Given this list of marker genes CST4, ACOT7, RAP2A, MDH1, HMOX2, NCAPH, CHD1L, EPAS1, VASH1, MRPL4, UQCRB, SREBF1, ATP1B1, GPR146, PCBP2, MAP2K6, GSE1, CBX6, ANKMY2, PRDX2, CNDP2, RAB33A, TMEM273, CBR3, PIAS2, HAVCR2, CBS, CD200R1, C1orf54, EPB41L2, NAGPA, SLC49A4, SAMD13, SLAMF9, CLASP2, RRP1B, ISOC2, CCDC6, ALDH1A2, HSD11B1, EEF1AKMT3, DIPK1A, RAD18, CD276, CD1B, AKAP5, TMC6, DHCR24, SCD (NCBI Gene Id 6319), CALCRL, AP3M2, HMG20B, B3GNT2, MYC, RAMP1, SLC16A1, TMCO4, SUCNR1, ITGAM, HSP90AB1, CTNNAL1, CCL22, SEPTIN11, ARL2, KLHDC9, SPP1, SGPP1, NIBAN1, CCDC92 (coiled-coil domain containing 92), EXTL2, CCL17 (NCBI Gene Id 6361), A2M, LINC02431, CD226, IL21R, CCND2, ADORA3, HIVEP3, CCDC85B, CFL2, SPN, TTL, CHCHD10 (NCBI Gene Id 400916), DHRS11, MLLT11, ERI1, ITPRIPL1, DNPH1, FOXQ1, MREG, HS2ST1, VAT1, KLF4, TPI1, BCO2, ZNF846, PPARGC1B, MIR503HG, DCSTAMP, C11orf21, MTHFD1L, HYCC1, PXYLP1, SYT17, TMEM266, SLC5A3, GALNT18, HEMK1, GDPD1, TBX19, PVT1, DNPEP, ILVBL, MAP3K21, GANC, C3orf18, HK3, CH25H, UQCRC1 (NCBI Gene Id 7384), SLC16A2, GARS1-DT, CLCN5, SENCR, PER2, NFIL3, PKD2, EFCAB11, C17orf58, ZNF571, MCUR1, LIMA1, CCL13, KHSRP, CSNK2B, UBE2F, ZNF93, SLC27A3, LNPK, CD81, PDCD1LG2, CD1A, SNHG33 (small nucleolar RNA host gene 33), FAM86B1, ATL1, WDR41, STUB1, NIPA1, RAP1GAP, MFHAS1, PCBD1, ZXDB, ZCCHC2, AUH, HOMER2, DEFB114, RHBDF1, CCL26, CD200, PRKD3, ADCK2, GOLGA8A, LDLRAD4, ROGDI, PER3, ZNF589, BCAR3, HSPB1, STARD4, JAG1, CLEC1A, RASAL2, ALOX15, CD209, ARAP2, STRADB, SNAI3 (snail family transcriptional repressor 3), NHLRC3, WFS1, NIFK-AS1, CRIP1, PFKP, TREM2, GTF2IRD1 (NCBI Gene Id 9569), GPI, CD1C, GSPT2, IFT172, SUOX, MRPS6 (NCBI Gene Id 64968), CDS2, SPINT2, ZNF124, ABCG2, VCPIP1, GOLM1, CAMK2D, SLC17A9, here is a description of the gene set: Temporal analysis of B cell activation in vitro using CD40L and IL-2/4/5 cytokines in wild type Irf4+/+ B cells or in mutant Irf4-/- B cells harboring a tet-inducible allele of Irf4. IRF4 expression was restored, or not, in the Irf4-/- background by culturing in the presence of low or high concentrations of doxycycline. The results provide insight in the role of IRF4 expression levels in coordinating different programs of B cell differentiation. from publication Ochiai K, Maienschein-Cline M, Simonetti G, Chen J, Rosenthal R, Brink R, Chong AS, Klein U, Dinner AR, Singh H, Sciammas R (PMID 23684984) Human Gene Set: GSE46606_IRF4_KO_VS_WT_CD40L_IL2_IL5_1DAY_STIMULATED_BCELL_UP studied in species Homo sapiens Genes up-regulated in CD40L and IL-2 IL-4 IL-5 stimulated at day 1 B cell IRF4-KO versus CD40L and IL-2 IL-4 IL-5 stimulated at day 1 B cell wildtype.